Given this list of marker genes PIK3R1, KLB, FGF8, FGF2 (NCBI Gene Id 2247), SOS1, FGF20, FGF19, NRAS, PIK3CA, GAB1, FRS2 (fibroblast growth factor receptor substrate 2), GRB2, FGF1, HRAS, FGF9, FGF6, PTPN11, FGF18, SHC1, FGF4, FGF23, FGFR4, FRS3, PLCG1, KRAS, FGF16, FGF17, here is a description of the gene set: studied in species Homo sapiens Downstream signaling of activated FGFR4 Human Gene Set: REACTOME_DOWNSTREAM_SIGNALING_OF_ACTIVATED_FGFR4